The following is a description of a gene set: Neighborhood of CSNK2B Human Gene Set: MORF_CSNK2B studied in species Homo sapiens Neighborhood of CSNK2B casein kinase 2, beta polypeptide in the MORF expression compendium, and this is the list of marker genes: NDUFS5, IMPDH1 (inosine monophosphate dehydrogenase 1), TCEA1, PHB2, NAA10, CSNK2B, NARS1 (NCBI Gene Id 9243), MPV17, NDUFV1, ATXN10, PRPS2, BANF1, ATP5MF, ARF3, DOCK3, PPP1R7, PTPN11, ERH, ATP5PF (NCBI Gene Id 63498), DEK, EI24, SYPL1, SNRNP200, DAP3, HMGN1, TARDBP, FEN1, EIF2B4, UQCRB, CYCS, NDUFC1, MRPL9, VPS52, NDUFS8, DARS1 (NCBI Gene Id 1615), AFG3L2, CLPP, RARS1, ATP5MC1, CALM3, COX6C, HDDC2, BAG6, HNRNPA2B1, UQCRC1, LAGE3, CHD4, SLC4A2, SNRPG, TUBB2A, TUFM, HADHA (hydroxyacyl-CoA dehydrogenase trifunctional multienzyme complex subunit alpha), AP3D1, PPM1G, GPX4 (NCBI Gene Id 2879), SNRPE, MCM7, HDGF, ALG8, LSS, STARD7, POLR2I, SOD1, HUWE1, EEF1E1, HSPA9, PRMT1, GNG5, RAC1 (NCBI Gene Id 5879), XPO7, SNRPA, FAM120A, RBM14, COX6A1, PTGES3 (prostaglandin E synthase 3), JTB, UQCRH, GNB1, MAEA, TBL3, SKP1, SUMO2, CAP1, SRSF9, RBBP4, SEC24C, NDUFS4, RALY, PRPF31, SSBP1 (NCBI Gene Id 6742), GNB2, MAP2K2, CTDNEP1, PCNA, COX5A, GGCT, COPE, HAX1, DHX16, IDH3G, KXD1, XRCC6, SDHA, LYPLA1, NDUFS1, KIF2A, LSM3, ELOC, NSDHL, SF3A1, SF3B2, NONO, LSM2, SNRPA1, TMEM147, PCLAF, LMNB2, HSPD1 (heat shock protein family D (Hsp60) member 1), TMBIM6, PPP1CA, ATP5F1D, ILF3, DDX49, ATP5MC3, COMMD4, COX4I1, HSP90AA1, UBA1, CS, NDUFB3, PSMB7, TMED9, ATP5PD, MTDH, SRSF1, UBAP2L, CANX, ACOT13, RNPEP, GMPS, NDUFS3, PTOV1, ATIC, PARK7, SLC3A2, HNRNPUL1, PSMB4, CLTA, DDX19B, VBP1, GLB1, VDAC1, SMARCD2, SMG7, BCAP31, DDX39B, COX6B1, G3BP2, EIF3B, SDHB, ANAPC5, NHP2, RAD21, HAT1, PPP2R1A, KPNA2, AKR7A2, PRRC2C, SLC25A3, RER1, RHEB, AP2S1, ATP5PO (NCBI Gene Id 539), SCAMP3, UBA2, GANAB, COX5B, CCT2, ATP5F1A, PSMD8, FIBP, NDUFV2, LSM4, ATP6AP1, EIF4A1, TECR, HNRNPC, EIF4B, DDOST, PSMB1, HCCS, SNRPD2, YWHAB, PDAP1, ERP29, HDAC1, HNRNPA3P1 (heterogeneous nuclear ribonucleoprotein A3 pseudogene 1), C1QBP, CHERP, NDUFAB1, EIF4H, SEM1, GPN1, ARHGDIA, RAD23B, BUB3, RAD23A, DRG1, SET, PUF60, TRIM28, CBX3, CYC1, ACLY, CDC123 (NCBI Gene Id 8872), HADHB, SRP9, DCTN2, SUMO1, GPI (NCBI Gene Id 2821), PRDX3 (NCBI Gene Id 29017), TAF11, UQCRC2, DAP (NCBI Gene Id 1611), CCT7, KHDRBS1, ACP1, DGUOK, URM1, RFC2, VDAC2, DHCR7, ESPL1, SEC13, VPS26A, NDUFS2 (NCBI Gene Id 4720), KDELR1, EIF4E2, ANP32B, CDK4, YWHAQ, KARS1, CCT3, UQCRFS1, IFRD1, BZW1, SNX3, DYNLL1, HNRNPAB, GLO1, RAN, MFAP1, AP2M1, CCT5, PDHB, EIF3C, ACOT7, DDX1, NRDC, PSMB2, CTBP1, AP3S1, SF3A2, FBL, COA1, UBE2L3, COPS5, LARP1, MBTPS1, TRAPPC3, YWHAE, EIF4G1, EIF3I, SRSF3, PSMD9, CDC23, RUVBL2, SLC1A5, EIF3K, FUS, PDCD6, MDH1, H2AZ1 (NCBI Gene Id 3015), H2AZ2, RBMX, U2AF1, MRPS18B